The following is a description of a gene set: electronically inferred by orthology from the curated human pathway part of: SLC-mediated transmembrane transport This event has been computationally inferred from an event that has been demonstrated in another species.<p>The inference is based on the homology mapping from PANTHER. Briefly, reactions for which all involved PhysicalEntities (in input, output and catalyst) have a mapped orthologue/paralogue (for complexes at least 75% of components must have a mapping) are inferred to the other species. Reactome Pathway: SLC-mediated transport of oligopeptides studied in species Mus musculus, and this is the list of marker genes: Slc15a3, Slc15a1 (solute carrier family 15 (oligopeptide transporter), member 1), Ctns